Given this list of marker genes AIP, PEX6, KCNJ11, PLIN1, GPR101, NSMCE2, ABCC8, MC4R (NCBI Gene Id 4160), ERF, CYP19A1, PDX1, CUL4B, POLR3A (RNA polymerase III subunit A), BUB1, PLAAT3 (phospholipase A and acyltransferase 3), ESR1, AFF4, CIDEC, CAV1, PEX1, AKT2, CLDN1, PCSK1, JARID2, FOS, HNF4A, NEUROD1, AGPAT2, COPB1, HRAS, SMARCD2, APPL1, PHLDB1, BSCL2, HNF1A, BLK, ALMS1, XRCC4, CHD8, PPARG, PKDCC, ELOVL1, PSMB8, ADRA2A, PAX4, POMC, SUPT16H, INS, APOA1, FGFR2, SPINK5, INSR, LMNA, GCK, CEL, CAVIN1, KLF11, JUP, PSMB4, HSD11B1, TFE3, FGFR3, LIPE, here is a description of the gene set: species: Homo sapiens Human Gene Set: HP_ACANTHOSIS_NIGRICANS A dermatosis characterized by thickened, hyperpigmented plaques, typically on the intertriginous surfaces and neck. Acanthosis nigricans